The following is a description of a gene set: GATA-2 is an essential transcription factor that regulates multiple aspects of hematopoiesis. Dysregulation of GATA-2 is a hallmark of acute megakaryoblastic leukemia in children with Down syndrome, a malignancy that is defined by the combination of trisomy 21 and a GATA1 mutation. Here, we show that GATA-2 is required for normal megakaryocyte development as well as aberrant megakaryopoiesis in Gata1 mutant cells. Furthermore, we demonstrate that GATA-2 indirectly controls cell cycle progression in GATA-1-deficient megakaryocytes. Genome-wide microarray analysis and chromatin immunoprecipitation studies revealed that GATA-2 regulates a wide set of genes, including cell cycle regulators and megakaryocyte-specific genes. Surprisingly, GATA-2 also negatively regulates the expression of crucial myeloid transcription factors, such as Sfpi1 and Cebpa. In the absence of GATA-1, GATA-2 prevents induction of a latent myeloid gene expression program. Thus, GATA-2 contributes to cell cycle progression and the maintenance of megakaryocyte identity of GATA-1-deficient cells, including GATA-1s-expressing fetal megakaryocyte progenitors. Moreover, our data reveal that overexpression of GATA-2 facilitates aberrant megakaryopoiesis. from publication Huang Z, Dore LC, Li Z, Orkin SH, Feng G, Lin S, Crispino JD (PMID 19620289) Genes up-regulated in G1ME cells (megakaryocyte/erythroid progenitor lacking GATA1) upon knockdown of GATA2 by RNAi. Mouse Gene Set: HUANG_GATA2_TARGETS_UP species: Mus musculus, and this is the list of marker genes: Arid3a, Kctd12, Adgrg3, Rab44, Hes6 (hairy and enhancer of split 6), Gpx1, Ap3s1, Mc5r, Cytip, Dok3, Atp6v0d1, H2-T23, Cox6a1, Tgfbr2, BC018473, Clec4d, P2ry14, Rhog, Trp53inp1, Tox, Adss1, Sft2d2 (SFT2 domain containing 2), Gdpd3, Eif1-ps3, Psenen, Cmtm7, Klk1b4, Ifi205, Aff1, Pik3cg, Tnfaip8l2, Tapt1 (transmembrane anterior posterior transformation 1), Il16, Prtn3, Tgfbr1, Cerk, Selplg, Scand1, Gyg1 (glycogenin 1), Ubl5, Dgkg, Satb1, Depp1, Iqgap2, Il17ra, Fut8, Spi1, Hhex, Samsn1, Ifitm1, Psmb9, Rin3, Akr1b10, Abtb1, Rab31, Cst3, Lat2, Kit, Atp6v0e, Sat1, Irak3, Tap2, Fam117a, Mgst2, Tspo, Cd244a, Srgn, Cpa3, Calml4, Cebpa, Evi2a (ecotropic viral integration site 2a), Emp3, Hp, Cd93, BC028528, Btg1, Gpr171, Sqstm1, Cdkn1b, Dynlt1b, Cd47, Sh3kbp1, Fis1, Bloc1s1, Tyrobp, Ifngr2, Gsn, Ypel5, Ank (progressive ankylosis), Gcnt2, Anxa2, Glipr1, Myo1f (NCBI Gene Id 17916), Ccl9, Ctse, Cdkn1a, Neurl3, Lgals1, Fcgr3, Lpxn, Mpo, Myl12b, Dap, Myl10, Fcgr2b, Grcc10, Psmb8 (proteasome (prosome, macropain) subunit, beta type 8 (large multifunctional peptidase 7)), Gabarap, Plac8, Ccpg1, Tmem50a, Txnip, Cd44, Sh3bgrl3, Macroh2a1, Prdx5, Alox5ap, Tpcn1, Gab1, Stard10, Plin2, Gabarapl1, B2m, Slc8b1, Pax6, Fam107b, Plec, N4bp2l1, Slc12a6, Gmfg, Arpc1a, Fes, Slc2a6, Tespa1, Napsa, Hbp1, Ffar2, Rnf130, Rps6, Gsto1, Uba6, Rab38, Clec4e, Acadm, Sipa1l1, St8sia4, Prorsd1, Lyz2 (lysozyme 2), Kcnn4, Tnfaip8, Tgif1, Ndufa6, Ndrg1, Greb1